The following is a description of a gene set: Catalysis of the reaction: 3'-phosphoadenosine 5'-phosphosulfate + heparan sulfate = adenosine 3',5'-bisphosphate + sulfated heparan sulfate. Mouse Gene Set: GOMF_HEPARAN_SULFATE_SULFOTRANSFERASE_ACTIVITY species: Mus musculus, and this is the list of marker genes: Ndst4, Hs3st3b1, Hs3st2, Hs3st3a1, Ndst3, Ndst2, Hs6st2, Ndst1, Hs3st6, Hs6st1, Hs2st1, Hs3st1, Hs3st4 (heparan sulfate (glucosamine) 3-O-sulfotransferase 4), Hs3st5 (NCBI Gene Id 382362), Hs6st3